The following is a description of a gene set: Human Gene Set: GOBP_REGULATION_OF_AMACRINE_CELL_DIFFERENTIATION studied in species Homo sapiens Any process that modulates the frequency, rate or extent of amacrine cell differentiation., and this is the list of marker genes: DLX1, DLX2, POU4F2, GDF11, TGIF1, TGIF2, HES1